Given this list of marker genes GTF3C6, RPS24P12, RPL35P3, ATP5MFP2, SCML4, TRAF3IP2-AS1, RNU6-653P, RNU6-770P, CEP57L1, LINC02518, SLC22A16, AK9 (adenylate kinase 9), MFSD4B, BVES, BVES-AS1, SOBP, POPDC3, ATG5, ENSG00000282408, RPSAP45, RN7SL617P, ARMC2-AS1, PTCHD3P3, RPL23AP50, RNU6-957P, PA2G4P5, RN7SKP211, CDC40, LINC02541, LINC00222, RNU6-437P, RPL7P28, FYN, ARMC2, MROCKI, RTN4IP1, RNU6-344P, ENSG00000287728, CDK19, MICAL1, RNU6-1144P, SEC63, CRYBG1, REV3L-IT1, PDSS2, ZBTB24-DT, QRSL1, RPF2, RNU6-1163P, RN7SL47P (RNA, 7SL, cytoplasmic 47, pseudogene), MTHFD2P3, METTL24, ZBTB24, RFPL4B, RNU6-1226P, FIG4, GPR6, CD164 (CD164 molecule), RPL21P65, RPL3P7, MTRES1, RPSAP43, FOXO3, PRDM1, LAMA4, RNA5SP211, SESN1, ENSG00000289961, HDAC2, CNN2P9, MARCKS, HDAC2-AS2, ENSG00000286914, RNU6-117P, LINC02836, BRD7P4, NR2E1, OSTM1, LINC02880, SNX3, GSTM2P1, ENSG00000296487, ZPR1P1, FEM1AP3, FAM229B, REV3L, NUDT19P3, RNU6-960P, FCF1P5, SLC16A10, LINC02527 (NCBI Gene Id 105377946), WASF1, RBISP4, CCDC162P, BEND3 (BEN domain containing 3), LINC02532, RNU6-527P, RPL7AP35, RNU6-1299P, SMPD2, TRAF3IP2, PREP, PPIL6, MIR587, SOCS5P5, MFSD4B-DT, CCN6, RNY3P11, KRT18P65, CD24, SUMO2P8, SNORA40C, ENSG00000307105, RNU6-1115P, FCF1P10, RNA5SP212, AFG1L, RPL36AP24, RNU6-1106P, RPS27AP11, DDO, AMD1, TUBE1, LAMA4-AS1, OSTM1-AS1, LINC02526, here is a description of the gene set: Human Gene Set: chr6q21 species: Homo sapiens